The following is a description of a gene set: part of: mRNA Editing: C to U Conversion studied in species Mus musculus Reactome Pathway: Formation of the Editosome This event has been computationally inferred from an event that has been demonstrated in another species.<p>The inference is based on the homology mapping from PANTHER. Briefly, reactions for which all involved PhysicalEntities (in input, output and catalyst) have a mapped orthologue/paralogue (for complexes at least 75% of components must have a mapping) are inferred to the other species. electronically inferred by orthology from the curated human pathway, and this is the list of marker genes: Apobec2, Apobec4, Apobec3